Given this list of marker genes GADD45A, AUTS2, C19orf84, SMG6, EIF4EBP2, TOM1L2, ARHGEF11, ZNRF1, KCTD7, PPP2R2D, CCL22, SUFU, MAPKBP1, HTR3C, PDXP, CD82, VEGFA, PCYT1A, SPRR2B, TBC1D8B, LINC02873, MRPL15, KRTAP5-10, AGO1, IFFO2, EXOC3L2, ESAM, STN1, FOXK1, GPATCH11, MYO1C, CNTN2, RGMA, CSNK1D, SPRR2A, HS3ST2, ADARB1, DUSP3, DDB1, FOXP4, SPOCK2, ZDHHC3, ZDHHC9, ASTN1, ZNF747, SV2C, FAHD2B, NFAT5, CDK14, DUSP18, HTR4, RAPH1, MAP1A, GNAO1, TRIP12, KMT2A, RAB3B, SPRR2D, WFDC10B, KDM4E, SYNJ2, SLC6A17 (NCBI Gene Id 388662), WNT2B (NCBI Gene Id 7482), RAPGEF3, TDO2, SLC6A6, RAP1GAP2, COL11A2, ZBTB4, B3GLCT, ZBTB34, SPINT3, NPR3, PRSS16, CLCN6, LBH, KIAA1671, SYN2, LRRC27, NGEF, CDPF1, MYRF, MAPK3, OSBP, SNRPD3 (small nuclear ribonucleoprotein D3 polypeptide), IL17RD, APBA2, NYNRIN, NBL1, GLIS3, NCCRP1, STRN4, NIBAN2, ABHD2, TMEM183A, INSM2, REEP4, GXYLT1 (NCBI Gene Id 338841), SPRR2E, SDC3, FAM222B, FLOT2, GREM1, KCNE1, LTA, TAP2, RCC2, FAM20A, MS4A18, CDK12, PIGZ, WDFY3, GANC, XPNPEP3, SMARCD1, CLN8, ZNF385A, NFAM1, MITF, RAPGEF1, BRAP, KRTAP5-2, KCNB1, CNIH4, DCC, SATB2, DDN, VWA5A, FANCC, BEND4, MFRP, ZNF70, RAPGEFL1, RPH3A, MEF2A, CNNM3, TNNI1, MTCL2, ATP1B2, PDE7B, PRICKLE1, ATP6V0D1 (NCBI Gene Id 9114), RUBCN, HAPLN4, PSMD9, ZNF444, FCHSD1, OMG, IKZF1, TMEM138, SZRD1, SKI, ZFR2, DDX6, TRIP6, TRIB2, NR1D2, IQCC, BCORL1, KBTBD13, MYLK4, C10orf105, HTR3E, PRRT2, LINC03040, GIT2, TTC39C (tetratricopeptide repeat domain 39C), MEF2D, SHISA7, NUTM2G, BBS1, ALX4, PLA2G2D, OPRM1, NMUR1, ZNF185, AEN, ARL17A, GLRA4, here is a description of the gene set: from publication Chen Y, Wang X (PMID 31504780) Genes predicted to be targets of miRBase v22 microRNA hsa-miR-4270 in miRDB v6.0 with MirTarget v4 prediction scores > 80 (high confidence targets). Human Gene Set: MIR4270 species: Homo sapiens